Given this list of marker genes ACTN1, SPTBN2, NEFH (neurofilament heavy chain), POTEJ, NEFL, ACTN2, ACTB, DLG1, ACTBL2, ACTG1, POTEKP, ACTL8, RAPSN, PPFIA2, POTEI (NCBI Gene Id 653269), POTEE, POTEF, GIT1, DBNL, INA, SHANK1, here is a description of the gene set: Human Gene Set: GOMF_STRUCTURAL_CONSTITUENT_OF_POSTSYNAPSE The action of a molecule that contributes to the structural integrity of a postsynapse. species: Homo sapiens